Given this list of marker genes TUBA3C, KIF18A, KIF12, KIF20A, TUBB8, TUBB6, TUBAL3, TUBB8B, KIF1C, KIF4A, TUBB2B, KIF4B, KIF9 (kinesin family member 9), KIF21A, KIF22, KIF16B, KLC4, TUBB3, KIF13B, TUBA3E, KIF11, KIFC2, KIF21B, TUBA8, KIFC1, TUBA1B, KIF3C, KIF2B, KIF20B, KLC3, KIF1B, KIF2C, KIF19, TUBB1, KIF5A, TUBB4B, KIF1A, CENPE, KIF27 (kinesin family member 27), KIF5B, TUBA4B, KIF3B, KIF26B, KIF3A, KLC2, KIF25, TUBA4A, KIF6, KIFAP3, TUBA1A, KIF15, RACGAP1, KLC1, TUBB2A, TUBB4A, KIF2A, KIF23, TUBA1C, KIF18B, TUBA3D, KIF26A, here is a description of the gene set: Kinesins studied in species Homo sapiens Human Gene Set: REACTOME_KINESINS